The following is a description of a gene set: Vitamins are a diverse group of organic compounds, required in small amounts in the diet. They have distinct biochemical roles, often as coenzymes, and are either not synthesized or synthesized only in limited amounts by human cells. Vitamins are classified according to their solubility, either fat-soluble or water-soluble. The physiological processes dependent on vitamin-requiring reactions include many aspects of intermediary metabolism, vision, bone formation, and blood coagulation, and vitamin deficiencies are associated with a correspondingly diverse and severe group of diseases.<p>Water-soluble vitamins include ascorbate (vitamin C) and the members of the B group: thiamin (vitamin B1), riboflavin (B2), niacin (B3), pantothenate (B5), pyridoxine (B6), biotin (B7), folate (B9), and cobalamin (B12). Metabolic processes annotated here include the synthesis of thiamin pyrophosphate (TPP) from thiamin (B1), the synthesis of FMN and FAD from riboflavin (B2), the synthesis of nicotinic acid (niacin - B3) from tryptophan, the synthesis of Coenzyme A from pantothenate (B5), features of the metabolism of folate (B9), the uptake, transport, and metabolism of cobalamin (B12), and molybdenum cofactor biosynthesis. species: Homo sapiens Reactome Pathway: Metabolism of water-soluble vitamins and cofactors part of: Metabolism of vitamins and cofactors, and this is the list of marker genes: FASN (fatty acid synthase), RNLS, PARP16, PARP8, ENPP3, ABCD4, AASDHPPT, PRSS1, NMNAT1, MMADHC, ALDH1L1, SLC22A13, SLC23A1, DCAKD, SLC25A32, NFS1, TCN1, GSTO1, PPCS, TPK1, THTPA (thiamine triphosphatase), PANK1, PDXK, SLC2A3, MTRR, SLC25A19, SLC52A2, MOCS2, DHFR2, CUBN, NUDT8, MTHFD1, PARP14, PRSS3, ACACA, RFK, AMN, MTHFD2, MCCC2, SLC5A8, ENPP1, MTR, SLC5A6, CYB5R3, MOCS3, SLC25A16, GPHN (gephyrin), NUDT12, SLC52A3, CBLIF (cobalamin binding intrinsic factor), VNN2, MCCC1, MTHFD1L, MTHFD2L, MMACHC, NADSYN1, BST1, TCN2, CD38, ACP5, AOX1, NAXD, COASY, ENPP2, PNPO, PPCDC, SHMT1, VNN1, SHMT2, NAMPT, NADK2, PCCA, PANK2, CTRB2, LMBRD1, MMAA, PARP10, HLCS, PARP9, NAPRT (nicotinate phosphoribosyltransferase), MMAB, FPGS, FLAD1 (NCBI Gene Id 80308), CTRB1, MOCOS, NT5E, NAXE, MOCS1, SLC19A3, NMRK2, ABCC1 (ATP binding cassette subfamily C member 1 (ABCC1 blood group)), FOLR2, NMNAT2 (NCBI Gene Id 23057), PDZD11, MTHFS, DHFR, ACACB, SLC52A1, PARP6, PCCB, SLC25A42, CYB5A, SLC23A2, CD320, NMNAT3, SLC2A1, NMRK1, SLC46A1, SLC19A2, PARP4, PANK3, PANK4, MMUT, LRP2, NADK, GSTO2, PC, MTHFR, SLC25A51, NNMT, SLC19A1, LDLRAP1, QPRT, ALDH1L2, BTD